The following is a description of a gene set: Any process that activates or increases the frequency, rate or extent of hematopoietic stem cell proliferation. species: Mus musculus Mouse Gene Set: GOBP_POSITIVE_REGULATION_OF_HEMATOPOIETIC_STEM_CELL_PROLIFERATION, and this is the list of marker genes: N4bp2l2, Prl2c3, Atxn1l, Thpo, Wnt10b, Pdcd2, Wnt5a, Wnt1, Kat7, Kitl, Cxcl1